The following is a description of a gene set: studied in species Homo sapiens A change in the morphology or behavior of a cell resulting from exposure to an activating factor such as a cellular or soluble ligand, leading to the initiation or perpetuation of an immune response. Human Gene Set: GOBP_CELL_ACTIVATION_INVOLVED_IN_IMMUNE_RESPONSE, and this is the list of marker genes: IL6R, BATF, STAT5A, VAMP3, GAB2, TNFSF13, MSH2, PHF14 (NCBI Gene Id 9678), SLAMF1, HLA-DRB1, LAT2, CR1, STAT3 (signal transducer and activator of transcription 3), FCGR2B, CD69, CLNK, LCP1, ADGRE2, KMT2A, IL13RA2, LFNG, HLX, KLRC2, EXOSC3, ZNF683, CDH17, FCER1A, KLRF2, ITGAM, TICAM1, SNAP23, FOXF1 (NCBI Gene Id 2294), CD1C, GPR183, APLF, JAK1, GPR65, IL27, IFNA21, JAK3, POU2AF1, LAMP1, CD80, IL10, IFNE, ADAM10, OPA1, RIF1, RASGRP1, PGLYRP1, RC3H2 (ring finger and CCCH-type domains 2), UNC13D, TSC1, DDRGK1, SOCS3, IFNW1, FER, GBF1, FGR, TNFSF4, IL12B, GRN, MTOR, CD40 (NCBI Gene Id 958), HLA-DRA, PRKCE, PLCG2, RIPK2, PYCARD, GRP, SEMA4A, APBB1IP, AP1G1, TNFSF18, HAVCR2, SANBR, TGFB1, EOMES, FCGR3A, CD244, LRP1, ZC3H12A, KMT5C, ICOSLG, IL18, IL12RB1, PGLYRP3, SH2D1B, SPN, PARP3 (poly(ADP-ribose) polymerase family member 3), VAMP2, CEACAM1, TREX1, SWAP70, PTGDR, HSPD1, GPR15LG (G protein-coupled receptor 15 ligand), SUPT6H (SPT6 homolog, histone chaperone and transcription elongation factor), ASCL2, CBL, MEN1, LILRB1, CCL19, PTGER4, PTPN6, ATP7A, VAMP7, SNX4, NCKAP1L, ATAD5 (NCBI Gene Id 79915), IL18R1, IGHE, GATA1, FOXP3, IL4, IFNA4, PSEN1, FERRY3, CD300A, SPI1, LGALS3, NFKBID, CLCF1, CLEC4E, DNASE1L3, TYROBP, LOXL3, CCR6, SLC11A1, IFNA8, DLL1, RABGEF1, KMT5B, MFNG, NSD2, SLC15A4, CD160, ST3GAL1, IL6, TNF, CD46 (CD46 molecule), LEF1, IL23R, KIT, MAD2L2, IFNA6, DOCK10 (dedicator of cytokinesis 10), RAB27A, ANXA3, CD74, ADORA2B, STXBP1, C17orf99, IFNL1, APP (amyloid beta precursor protein), ENTPD7, CRACR2A, SHB, CD180, FES, RAC2, LBP, CLEC4D, BRD2, CX3CR1, SOCS5, PRAM1, LAT, CD86 (NCBI Gene Id 942), PRKCZ, IFI35, TMEM98, PMS2, CD40LG, TREM2, PLXNA1, IFNA16, IFNB1, SPHK2, PCYT1A, S100A13, RARA, PTPRC, GKN2, PLCL2, RORA, ENPP3, MILR1, DOCK11, TP53BP1, GATA3, IRF4, STX4, STXBP3, FOXP1 (NCBI Gene Id 87246), IFNA14, SBNO2, SYK, LY9, BCR, HLA-DMB, IL23A, PCK1, RNF168, CD81, IFNA10, MYD88, CCL3, IFNG, SLAMF6, FCER1G, LILRA2, EXO1, SEMA6D, TP53, NFKBIZ, RORC, EXOSC6, NLRP3, UNG, IL33, IRF8, NKG7, PDP2, FGL2, PTGDS, ABL1, SHLD3, BRD4, SHLD1, CD19, RELB, ITM2A, TBK1 (TANK binding kinase 1), SHLD2, BTK, CD84, CORO1A, ANXA1, PTK2B (protein tyrosine kinase 2 beta), GATA2, MIR21, TCIM, JUNB, VAMP8, NOTCH2, STAT6 (NCBI Gene Id 6778), HMGB1, NDFIP1, IFNA5, KARS1, LGALS9, MLH1, IFNA2, BCL3, IFNA1, TFRC (NCBI Gene Id 7037), TAOK3, LGALS8, RC3H1, PDPK1 (3-phosphoinositide dependent protein kinase 1), CCR2, SCN11A, CD177, ITGB2, ERCC1, DOCK2, STXBP2, PIK3CG, BCL6, RAB44, HMCES, HLA-F, IL21, ICAM1, MALT1, ITGAL, TLR4, ADA, SMAD7, LGALS1, IL6ST, MRGPRX2 (NCBI Gene Id 117194), ITFG2, SLC18A2, NBN, NKX2-3, NMI, PGLYRP2, PAXIP1, PIK3R1, IL13, PLA2G3, SNX6, ZBTB7B, SCNN1B, EIF2AK4, IFNA7, CPLX2, IL2, RNF8, ZFPM1, CD28, F2RL1, PIK3CD, IFNA17, MDK, CHGA, XBP1, ICOS, TBX21, EP300, DNASE1 (NCBI Gene Id 1773), AICDA, RAG2, DYSF, GAPT, MSH6, LYN, SUCNR1, IL27RA, IFNK (interferon kappa), LIG4, IL4R, MYB, STAT4, NR4A3